The following is a description of a gene set: The chemical reactions and pathways involving phospholipids, any lipid containing phosphoric acid as a mono- or diester. Mouse Gene Set: GOBP_PHOSPHOLIPID_METABOLIC_PROCESS studied in species Mus musculus, and this is the list of marker genes: Dpm1, Cds1, Flvcr1 (NCBI Gene Id 670389), Gdpd1, Pitpnc1, Mtm1, Dpm2, Fgf7, Etnk1, Pik3cd, Sgms1, Pdgfb, Pnpla7, Inpp5a, Pla2g15, Idi1, Ptdss2, Plcl1, Plch2, Ldlr, Gpat4, Lrat, Acp6, Mvk, Arf1, Dgkb, Bpnt2, Htr2c, Pigf, Mfsd2a, Pik3c2a, Pik3r4, Lpcat2, Plpp2 (phospholipid phosphatase 2), Adgrf5, Pld1, Inpp5f, Pigo, Selenoi, Bscl2, Ip6k3, Lpin1, Plcb3, Sphk2, Tmem150a, Pik3cg, Pla2g2c, Hadha, Pip4k2c, Chpt1, Gpat2, Smpd5, Ipmk, Chka, Scarb1, Gnpat, Apoc2l (NCBI Gene Id 105886299), Inpp4b (inositol polyphosphate-4-phosphatase, type II), Them5, Cyp2w1, Lcat, Inpp5e, Fitm2, Serinc4, Pla2g4d, Tmem38b, Pcx, Pla2g10, Pigg, Abca3, Plpp1, Smpd3, Pld2, Hmgcs2, Itpkc, Pgap2, Pla2g3, Plaat3, Pcyt2, Etnppl, Itpkb, Plcb4, Gdpd3, Dnajc19, Slc30a5, Mtmr10, Idi2, Smpd1 (sphingomyelin phosphodiesterase 1, acid lysosomal), Sh3glb1, Agap2, Ptdss1, Pla2g2a, Crls1, Mtmr7 (NCBI Gene Id 54384), Plbd2, Apoa2, Tnxb, Lpcat2b, Sacm1l, Pgap1, Pgs1, Sgms2, Mtmr1, Pnpla6, Pdgfa, Pip4p2, Pisd, Plscr3, Plaat1, Nr1h3, Pigc, Dhdds, Ajuba, Pigv, Plscr1 (phospholipid scramblase 1), Slc27a1, Atm, Pigh, Nus1, Tafazzin (tafazzin, phospholipid-lysophospholipid transacylase), Abca8a, Lipc, Pik3c2g, Naaa, Mboat1, Pmvk, Hdhd5, Dgki, Pigp, Pik3r1, Pip5k1a, Plpp3, Ptpmt1, Pip4k2b, Dpm3, Pla2g5, Gata6, Mtmr4, Serinc5, Cln8, Enpp7, Pnpla8, Pi4k2a, Abhd16a, Erbb4, Pla2g1b, Becn1, Abhd4, Mboat7, Plpp5, Serinc2, Pla2g4b, Pi4ka, Agpat2, Plce1, Pi4k2b, Abhd16b, Pla2g2f, Serac1, Lpcat3, Inpp5d, Gpcpd1, Mtmr9, Pon1, Lclat1, Acsl5, Pip5k1c, Dgkd, Agpat3, Pigw, Lyst, Ttc7b, Abhd8, Plek, Hycc1, Plcb1, Pign, Ocrl, Pla2g2d, Mecp2, Cln3, Scp2, Pigl, Fdft1, Mtmr2, Inpp5k, Hycc2, Htr2a, Bloc1s6, Pla2g2e, Napepld, Samd8, Cdipt, Chkb, Smg1 (SMG1 nonsense mediated mRNA decay associated PI3K related kinase), Pigq, Nkx2-1, Alox15, Fig4, Pik3c3, Apoc2, Pigk, Lpcat4, Abhd5, Prdx6b, Pigyl, Itpka, Fabp3, Isyna1, Smpdl3a, Osbp, Mtmr11, Plppr5 (NCBI Gene Id 75769), Oc90, Abca2, Enpp2, Hexb, Plppr3, Angptl3, Pgap3, Pigt, Apoa1, Piga, Pnpla3, Synj2, Abca8b, Serinc1, Pigu, Vac14, Pla2g6, Plcg2, Dgkq, Pgp, Pla2g4c, Ddhd1, Gpat3, Tamm41, Pik3ca, Plb1, Synj1 (synaptojanin 1), Cwh43, Ip6k2, Tnfaip8l3, Sh3yl1, Gpam, Gpld1, Prkcd, Inpp4a, Idh1, Plpp4 (NCBI Gene Id 403184), Pip4k2a, Plcd1, Abhd6 (NCBI Gene Id 98228), Mtmr12, Nr1h2 (nuclear receptor subfamily 1, group H, member 2), Plppr2, Gnb3, Dhrs7b, Plppr1, Vapa, Efr3b, Pcsk9, Pla2g12a, Pigx, Gpaa1, Bpnt1, Pyurf, Agpat5, Aspg, Dgkk, Pik3r5, Pla2g4a, Plaat5, Impa1, Plbd1, Snca, Pten, Plcb2, Ip6k1, Pla2g4e, Pdgfrb, Ttc7, Etnk2, Spata18, Pcyt1b, Dgkg, Pip4p1, Pigz, Lpgat1, Smpd2, Pip5kl1, Pemt, Pik3c2b, Inpp5j, Dgkh, Ppard, Plcg1, Plpp6, Plppr4, Pip5k1b, Htr2b (NCBI Gene Id 98641), Chrm5, Smpdl3b, Dbi, Pigb, Pikfyve, Abhd3, Dgkz (diacylglycerol kinase zeta), Pigm, Ormdl1, Agpat1, Sgpp1, Pnliprp2, Dgke, Agpat4, Chp1, Apoc1, Cds2, Plch1, Far1, Fitm1, Mtmr6, Phb2, Rab38, Fabp5, Dolk, Pla2g7, Acsl3, Prdx6, Mtmr3, Sptlc1, Atg14, Cept1, Ptprq, Acsl6, Capn2, Uvrag, Ormdl3, Fdps, Inpp5b, Abhd12b, Mppe1, Plcd4, Proca1, Hmgcs1, Smpd4, Mboat2, Dgka, Alox8, Impa2, Pla2g12b, Pcyt1a (NCBI Gene Id 13026), Gde1, Inpp1 (inositol polyphosphate-1-phosphatase), Lpcat1, Inppl1, Plcl2, Sptlc2, Galr2, Pi4kb, Apoa4, Pgap4, Mvd, Nr1h4 (NCBI Gene Id 20186), Pik3cb, Ggps1, Pigs, Abhd12 (abhydrolase domain containing 12), Pla2g4f